Given this list of marker genes GTF2H3, GTF2H5, POLR2J, POLR2L, CTDP1, ELOB, POLR2C, ELL, POLR2A, SUPT16H, NCBP1, POLR2H, CDK7, NELFB, tat, CCNT1, CCNH, GTF2F1, NELFCD, POLR2K, ELOC, ERCC3, TCEA1, SUPT5H, SSRP1, CDK9, NCBP2, NELFA, POLR2B, POLR2E, GTF2H4, SUPT4H1, GTF2H2, ERCC2, ELOA2, POLR2G (RNA polymerase II subunit G), POLR2I, GTF2F2, POLR2F, GTF2H1, MNAT1 (MNAT1 component of CDK activating kinase), POLR2D, NELFE, ELOA, here is a description of the gene set: species: Homo sapiens Reactome Pathway: Tat-mediated elongation of the HIV-1 transcript The Tat protein is a viral transactivator protein that regulates HIV-1 gene expression by controlling RNA Pol II-mediated elongation. Tat appears to be required in order to overcome the arrest of RNA Pol II by the negative transcriptional elongation factors DSIF and NELF. While Pol II can associate with the proviral LTR and initiate transcription in the absence of Tat, these polymerase complexes are non-processive and dissociate from the template prematurely producing very short transcripts. Tat associates with the RNA element, TAR, which forms a stem loop structure in the leader RNA sequence. Tat also associates with the cellular kinase complex P-TEFb(Cyclin T1:Cdk9) and recruits it to the TAR stem loop structure. This association between Tat, TAR and P-TEFb(Cyclin T1:Cdk9) is believed to bring the catalytic subunit of this kinase complex (Cdk9) in close proximity to Pol II where it hyperphosphorylates the CTD of RNA Pol II. The RD subunits of NELF and the SPT5 subunit of DSIF, which associate through RD with the bottom stem of TAR, are also phosphorylated by P-TEFb(Cyclin T1:Cdk9). Phosphorylation of RD results in its dissociation from TAR. Thus, Tat appears to facilitate transcriptional elongation of the HIV-1 transcript by hyperphosphorylating the RNA Poll II CTD and by removing the negative transcription elongation factors from TAR. In addition, there is evidence that the association of Tat with P-TEFb(Cyclin T1:Cdk9) alters the substrate specificity of P-TEFb enhancing phosphorylation of ser5 residues in the CTD of RNA Pol II. part of: HIV Transcription Elongation